Given this list of marker genes BCKDK, EIF2S1, LPP, BMAL2, SMCO4, CLIP4, ALCAM, WDR3, ABHD6, ANKRD11, PEPD, ALG3, POLD1, ZBTB43, ZNF446, CBR3, SIDT2, ZNF706, WDR18, WDR12, MTX1, TST, LDB1, ADAM12, COMP (cartilage oligomeric matrix protein, NCBI Gene Id 5659), SCARB2, QSOX1, HIVEP3, BSCL2, CERS6, DIAPH2, ZNF141, SEPTIN9, IARS1, CDH12 (cadherin 12), IL10, SLC1A3, PCK2, KMO, ATP10A, CAMK2A, DRAM1, TRIAP1, TRPV2, SLC20A1, VPS41, SGSH, ILVBL, CYB5R3, RGCC, ADO, GH1, PXMP2, CDC42BPB, CELSR1, STXBP1, MAN2B1, HUNK, MERTK, MTMR8, SLN, ME3, LAMC3, AIMP2, NRGN, CCL22, PCOLCE2, DUSP7, FAXDC2, CD36, FBXO21, SPSB1, ZNF43, CTSH, PEBP1, CBR1, HIF1AN, FKBP9, ACVR2A, CCDC92, CCL17, CD1C, SHQ1, PDSS2, ATP6V1D, QDPR, ST8SIA2, ROBO3, ITPKB (NCBI Gene Id 3707), H3C11, TIAM1, COL14A1, TMCC1, TMEM161A, NQO1, PDE8A, PGAM1, IGFLR1, TNS1, PLA2G4C, MCUR1, PSG5, ORC6, NDUFB8, LTA4H, GM2A, ANTKMT, SEPTIN8, PPP2R3A, SLC31A1, GTF2IRD1, GAST, MAOA, HBEGF, CTSL, GLB1, FPR3, PREPL, WDR77, OGDH, PER2, KYNU, YIF1A, CHI3L1, TBX6, ABCC3, GRM3, CDYL, ENO1, ASAP1, MYOF, VPS37C, MBNL3, ARHGEF10L, SNED1, ESD, MEF2C, DBT, CD83, ATP6V1B2 (NCBI Gene Id 526), ACOT7, NANS, MKLN1, PRSS50, HSD3B1, GPNMB, MAOB, ARMCX5, AGBL3, INHBA, RTN2, HCK, CYBB, DDO, DARS1, PPARG, TRIP6, IMPDH1, MIPEP, CYBA, CPNE3, CEMIP, PHACTR4, NPC1, MORC2, C1QA, MATK, DYSF, SCGB1A1, GLG1, WARS1, ASCC3, KLHL22, ABHD2, SPRY2, MRPL57, HPCAL1, FGFR4, SMIM7, RAI14, MCCC2, HSPD1, GRN, FASTKD2, SNX5, TMEM8B, ADAP1, KCNQ1, GAA, BRD3OS, POLQ, NTAN1, PTGS1, AP5S1, JHY, RRAS, ATF3, TROAP (trophinin associated protein), GALNT12, here is a description of the gene set: Human Gene Set: GSE3982_DC_VS_BASOPHIL_UP Genes up-regulated in comparison of dendritic cells (DC) versus basophils. In the present study we used Affymetrix oligonucleotide microarrays to produce gene transcription profiles for the major leukocyte types in humans. This comprehensive dataset enabled us to not only establish which genes were expressed in each leukocyte type, but also which genes were expressed in each subset after activation. The used of a comprehensive dataset of gene profiles from all the major human leukocyte subsets enabled a novel and powerful means for identification of genes associated with single leukocyte subsets, or different immune paradigms. studied in species Homo sapiens from publication Jeffrey KL, Brummer T, Rolph MS, Liu SM, Callejas NA, Grumont RJ, Gillieron C, Mackay F, Grey S, Camps M, Rommel C, Gerondakis SD, Mackay CR (PMID 16474395)